Given this list of marker genes Rnf185, Pdlim1, Zmynd8, Agap1, Dzip1, P4ha3 (NCBI Gene Id 320452), Mef2d, Vps28, Lypd11, H2-T22, Hykk, Scn3b, Syt14, Prss43, Arhgef6, Cipc (NCBI Gene Id 71935), Gm128, Zfp366, Ncam2, Itgav, Ddr2, G6pc1, Trim60, Zscan12, Nkx3-1, Pianp, Pld2, Mrtfa, Zfand2a, Rxfp2, Chrna4, Fgfr1, Bahd1, Cnfn, Tdrkh, Klhl18, Abat, Cd177, Lyrm4, Urad, Nipal3, Srgap1, Hpca, Iqsec2, Arl8b, Cox10, Opn3, Clec7a, Ibtk, Slc4a8 (NCBI Gene Id 59033), Mphosph9, Ptprj, Slc38a10, Nrn1, Ncln, Cdc40, Slc26a1, Nr6a1, Anapc2, Mri1, Zfp148, U2af2, Lypd10, Adgra1, Vegfa, Grik3, Inhbb, Agr2, Rab11fip3, Sema4g, Zyx, Nanos2, here is a description of the gene set: Genes predicted to be targets of miRBase v22 microRNA mmu_miR_698_5p in miRDB v6.0 with MirTarget v4 prediction scores > 80 (high confidence targets). from publication Chen Y, Wang X (PMID 31504780) Mouse Gene Set: MIR_698_5P studied in species Mus musculus